Given this list of marker genes Gad1, Mag, Gamt, Sst, Ncor1, Dlx5 (NCBI Gene Id 13395), Smc3, Csrp1, Oprk1, Ezh2, Hnrnph1, Sp3, Ybx1 (Y box protein 1), Cebpd, Rest, Tap1, Grin1, Bdnf, Fgf3, Apoc2, Rbfox1 (RNA binding protein, fox-1 homolog (C. elegans) 1), Tet1, Fut8, Taf1, Sp1, Mecp2, Gprin1, Prpf3, Nf1, Hnrnpf, Fgf4, Creb1, Mbp, Myt1, Ctcf, Fgf2, Mef2c, Gabrr2, Nrep, Cdon, Arhgef26, E2f1, Bcl6, Sin3a (transcriptional regulator, SIN3A (yeast)), Cnp, here is a description of the gene set: studied in species Mus musculus Mouse Gene Set: WP_MECP2_AND_ASSOCIATED_RETT_SYNDROME Mecp2 and associated Rett syndrome